The following is a description of a gene set: studied in species Homo sapiens Fasciculations are observed as small, local, involuntary muscle contractions (twitching) visible under the skin. Fasciculations result from increased irritability of an axon (which in turn is often a manifestation of disease of a motor neuron). This leads to sporadic discharges of all the muscle fibers controlled by the axon in isolation from other motor units. Human Gene Set: HP_FASCICULATIONS Fasciculations, and this is the list of marker genes: MATR3, ERLIN1, FBXO38, UCHL1, SYNE1, NOP56, CACNA1A, ATP2A1, PPARGC1A, NDUFS4, GLRB, SCN4A, MPZ, TAF15 (NCBI Gene Id 8148), SMN2, HSPB1, PSAP, AIFM1, TTC19, SMN1, HNRNPA1, EXOSC9, CRYAB, COL25A1, VPS13D, MED11, SH3TC2, MORC2, PON1, MPV17, PON2, CHCHD10, TOE1, TBCD (tubulin folding cofactor D), PNPLA2, GLRA1, ADPRS, GRN, DCTN1, ATP1A2, SLC25A21, PRX, SLC6A5, ANXA11, ATXN3, LGI3, EEF2, PMP22, NF2, ELOVL4, TBK1, GLA, AGTPBP1, LZTR1, LRP12, NEFH, JAG1, KIF1C, MAPT, PRRT2, PON3 (paraoxonase 3), SCYL2, ERBB4, COQ7, SCO2, SQSTM1, MINPP1, VRK1, SCN1A, LRSAM1, TREM2, SLC52A2, MUSK, CPLANE1, SYT2, SPG11, SLC25A46, ATXN1, MEGF10, GPHN, ANG, HINT1 (histidine triad nucleotide binding protein 1), FXR1, ATP11A, FIG4, CCNF, EXOSC8, SOD1, HEXB, KCNK9, CEP126, AR, PFN1, OPTN, MARS1, VWA1, NEK1, PRUNE1, TFG (trafficking from ER to golgi regulator), ASAH1, PRPH, CHMP2B, EXOSC3, COQ6, ATAD1, SMARCB1, HACE1, FUS, BICD2, NEFL, DENND5A, TARDBP, VCP, SPTLC1, GLE1, HNRNPA2B1, CFAP410, DAO, TMEM106B, PSEN1, UNC13A, ATXN2, UBQLN2, VAPB, RMND1, SLC52A3, UBA1, ANO10, RYR1, VPS41, RAB7A, ATXN10, EGR2, GLT8D1, DMD, TSPYL1, ERGIC1